Given this list of marker genes Slc25a13, Mt3 (NCBI Gene Id 17751), 1810024B03Rik, Stoml2, Ppargc1a, Gck, Il10rb, Uqcrb, Lep, Myc, Ndufs3, Adsl, Vcp, Pum2, Uqcr11, Ndufs4, Cox7a1, Etfdh, Nop53, Cox4i2, Macroh2a1, Myog, Trap1, Ak4, Atp7a, Ndufb9, Ndufa7, Mtor, mt-Co2, Adhfe1, Coa6, Idh3a, Oas1a, Mup4, Sdha, Slc25a51, Tnf, Tigar, Ndp, Tcf7l2, Akt1, mt-Nd5, Ccnb1-ps, Mup1, Ppp1r3c, Blvra, Mtch2, Dyrk2, Sdhc, Ogdh, Gys1, Adrb1, Dld, Pcdh12, Mfsd8, Ppp1r2, Fxn, Ppp1r3b, Antkmt, Wipi2, Cdk1, Ndufa11, mt-Atp6, mt-Nd2, Ndufa8, Apoc3, Ndufa9, Mdh1, Ndufb3, Ppp1r3d, Dguok, Ndufv2, Cavin3, Shmt2, Ndufs6, Inpp5k, Bloc1s1, Mup5, Cox8a, Uqcrh, Chchd4, Epm2a (epilepsy, progressive myoclonic epilepsy, type 2 gene alpha), Kl, Chchd2, Gsk3a, Gfpt1, Ndufa6, Nfatc3, Cox7a2l, Mir451b, mt-Atp8, Ndufa1, Pm20d1, Suclg2, Eva1a, Etfb, Esrrb, Lepr, Comt, Chchd2-ps, Atp5f1c, Gys2, Nfatc4, Il6st, Chchd10, Adcy10, Pink1, 1700066M21Rik, Snca, Dnajc15, Ndufs7, Rb1cc1, Vps54, Fh1, Sod2, Bid, Pygb, Dnajc30, Ppp1r1a, Bax, Igf2, Prdm16, Cbfa2t3, Uqcrfs1, Ndufb7, Cox10, Atp6-ps, Cox6a1, Ndufb4, mt-Cytb, Mup11, Lyrm7, Dlat, Ndufa5, Gnas, Tmem135, Ndufab1 (NCBI Gene Id 72270), Atp5pb, Hmgb1, Slc25a12, Oas1g, Trex1, Mtfr1, Gcgr, Ppp1cb, Oas1d, Pdha1, C1qtnf2, Atp5f1a, Mup2, Irs2, Msh2, Oas1h, Rhoa, Atp5pf, Slc37a4, Ppp1cc, Adgrf5, mt-Co1, Adra1b, Pgm1, Ugp2, Ptges3, Ifnar1, mt-Nd4l, Pik3ca, Gabarapl1, Cs, Atp5po, Pgf, Atg2b, Atg2a, Arl2, Ppp1r3a, Cycs, Dlst, Cox6b2 (cytochrome c oxidase subunit 6B2), Cox7b, Pdha2, Afg1l, Trp53 (NCBI Gene Id 22059), Ins2, Stk40, Atp5pd, Ins1, Insr, Atp5f1e, Gba1, mt-Nd6, Immp2l, mt-Nd1, Uqcrq, Cox5a, Mlxipl (NCBI Gene Id 58805), Uqcrc1, Coq7, Cox7a2, Atg3, Mtfr1l (mitochondrial fission regulator 1-like), Mup3, Oas1c, Ndufb5, Aifm1, Mrap2 (NCBI Gene Id 640967), Slc25a25, Cox4i1, Idh1, Oas1f, Chchd5, Phkg1, mt-Nd3, Idh3b, Cox8b, Agl, Ccnb1, Uqcrc2, Cyct, mt-Nd4, Ppp1r3f, Abcc9, Bcl2l13, Khk, Atp5mf, Ndufa10, Ndufb2, Pnpt1, Adgrf1, Irs1, Gbe1, Tafazzin, Trpv4, S100b, mt-Co3, Ndufs8, Cox6c, Atp5f1b, Sdhaf4, Sco2, Ide, Ndufc1, Ndufa3, Iscu (iron-sulfur cluster assembly enzyme), Mtfr2, Ogdhl, Gsk3b, Nr1d1, Cox7c, Cat, Atg12, Opn3, Cyc1, Ndufaf1, Abcd1, Ndufb8, Pygm, Ifnlr1 (NCBI Gene Id 242700), Mybbp1a, Selenon, Prkaca, Sorbs1, Ndufa13, Mfn2, Jmjd8, Ppp1ca, Idh2, Oas1e, Pth, Mdh1b, Prelid1, Uqcc3, Prlh, Idh3g, Pfkm, Plec, Ndufv3, Coq10b, Nr4a3, Phlda2, Pank2, Igf1, Cox6a2, Pygl, Per2, Ndufs1, Etfrf1, Ndufa2, Gnmt, Akt2, Bdnf, Ucn, Mc4r, Pde2a, Ppp1r3e, Pgm2, Mdh2, Aco1 (aconitase 1), Mtln, Sdhaf2, Phka1 (phosphorylase kinase alpha 1), Prkag2, Gaa, Ppif, Atp5me, Atp5if1, Sdhb, Ndufs2, Phkb, Uqcc2, Wipi1, Mir451a, Park7, Actn3 (actinin alpha 3), Aco2, Ifng, Uqcr10, Pask, Acadm, Cox7b2, Col6a1, Rubcnl (RUN and cysteine rich domain containing beclin 1 interacting protein like), Ppp1r3g, Cox6b1, Oxa1l, Ndufc2, Ndufs5, Ndufb10, Nipsnap2, Aifm2, Phka2, Tefm, Oas1b, Slc25a23, Cox5b, Cox8c, Ndufb1, Sdhd, Gyg1, Phkg2, Sucla2, Il4, Prkag3, Ndufa12, Norad, Ndufb11, 4933405O20Rik, Pdhb, Csl, G6pc1, Cyp1a2, Ndufb6, Atp5f1d, Nupr1, Ndufv1, Grb10, Etfa, Epm2aip1, Ldha, Pomc, Atpsckmt, Mrps36, Slc25a33, Wdr45b, Coq9, Enpp1, Wdr45, Sirt3, Nhlrc1, Cisd1, Suclg1, Stbd1, Hoxb3os, here is a description of the gene set: species: Mus musculus The chemical reactions and pathways by which a cell derives energy from organic compounds; results in the oxidation of the compounds from which energy is released. Mouse Gene Set: GOBP_ENERGY_DERIVATION_BY_OXIDATION_OF_ORGANIC_COMPOUNDS